The following is a description of a gene set: Dextrotransposition of the great arteries A type of transposition of the great arteries (TGA) in which aorta is in front of and primarily to the right of the pulmonary artery. This is the most common kind of TGA. Human Gene Set: HP_DEXTROTRANSPOSITION_OF_THE_GREAT_ARTERIES studied in species Homo sapiens, and this is the list of marker genes: SMAD2, NODAL, CIROP, SMG9, ZIC3, ACVR2B, ZNF462